Given this list of marker genes Neurl4, Trp53, Atg7, Sesn2, Twnk, Mtnap1 (mitochondrial nucleoid associated protein 1), Chchd4, Tk2, Dnaja3, Mpv17, Top3a, Dna2, Mgme1, Rrm2b (NCBI Gene Id 382985), Lig3, Endog, Parp1 (NCBI Gene Id 98479), Rnaseh1, Rrm1, Ssbp1, Mettl4, Cfh, Stox1, Polg2, Polg, Primpol, here is a description of the gene set: The chemical reactions and pathways involving mitochondrial DNA. studied in species Mus musculus Mouse Gene Set: GOBP_MITOCHONDRIAL_DNA_METABOLIC_PROCESS